Given this list of marker genes Ppp2r5b, Ppp2r5a, Ptpn11, Fgr, Lrp8, Ppp2r1a (NCBI Gene Id 76182), Ppp2ca, Ppp2r1b, Pla2g4a, Ppp2r5c, Ppp2cb, Apob, Mapk14, Pecam1, Ppp2r5e (protein phosphatase 2, regulatory subunit B', epsilon), Ptpn6, Ppp2r5d, here is a description of the gene set: Mouse Gene Set: REACTOME_PLATELET_SENSITIZATION_BY_LDL studied in species Mus musculus Platelet sensitization by LDL